Given this list of marker genes Jade1, Naf1, Uhmk1, Trim15, Tmem30a, Gm4836, Aldoart2, Gm14632, Gm10147, Ppp1r8, Dnajc9, Ccdc80, Gm10230, Gm10487, Lrrtm2, Cflar, Gm10488, Sltm, Gm10058, Gm10096, Sorbs1, Gpm6b, Pax3, Picalm, Septin10, Sprr3, Gm10486, Dennd4c, Mecp2, Srsf7, Mdga1, Trem3, Gm5916, Phf20l1, Lemd3 (LEM domain containing 3), Cmtm3, B3gnt6, Gm14819, Vsnl1, 4930426D05Rik, Cxxc5, Hmox1 (NCBI Gene Id 27970), Slc38a2, Pate5, Pank3, Depdc1a (DEP domain containing 1a), Wt1, Mmaa, Golga7, here is a description of the gene set: Mouse Gene Set: MIR_872_5P Genes predicted to be targets of miRBase v22 microRNA mmu_miR_872_5p in miRDB v6.0 with MirTarget v4 prediction scores > 80 (high confidence targets). from publication Chen Y, Wang X (PMID 31504780) species: Mus musculus